Given this list of marker genes Nrg1, Mt3, S100a7a, Prm2, Fth1, Casq2, Slc39a4, Nucb2, Lcn2, Myt1l, Naglu, here is a description of the gene set: studied in species Mus musculus Mouse Gene Set: GOMF_METAL_ION_SEQUESTERING_ACTIVITY Binding to a metal ion to prevent it from interacting with other partners or to inhibit its localization to the area of the cell or complex where it is active.